Given this list of marker genes EPM2AIP1, LRRC41, ELOA2, PIGN, USP49, NEK10, WEE1, RTKN2, ASH1L, COL1A1, HDAC9, ZFP28, IL1RN, ESRRG, EMP2, TAGAP, ATP6V1A (ATPase H+ transporting V1 subunit A), UBE4B (NCBI Gene Id 10277), BRWD1, SLITRK2, KIAA1217, RBM20, RUNX1T1, PAPSS1, CD164, EFL1, CBX5, HCN1, FBXO8, ZNF154, NRP2, KLF7, BRINP1, ELFN2, SRGAP1, OSBP, SERINC5, KDM5B, NEXN, AAGAB, SORBS1, HECW1, CNTN4, SOAT1, DNAAF2, TRERF1, KRT34, SLF2, AMOTL1, PCYT1A, DDX60L, WDR3, GNG4, ZDHHC9, HGSNAT, LRRC8C, RORA, FBXO5, FBXL5, TGFBR1, RSPH3, PABIR1, GRIK3, PALM2AKAP2, KALRN, SEL1L, LPCAT2, SSU72, GPIHBP1, PTPRB, DNAJA3, STK38, PCNP, PIAS1, ACTR2, ATOSA, LIN54, ESR1, RIPOR2, SMC2, BECN1, ZBTB1, ZNF236, ARRDC3, TMEM245, N4BP1, KLHL14 (NCBI Gene Id 57565), C4orf51, SEPSECS, EGR3, NETO2, C3AR1, CBL, EGLN3, NFIA, AGO1, AGPAT3, STARD5, HLF, UNC119, ALDH6A1, SEZ6 (seizure related 6 homolog), UGT2A1, ZC4H2, AFF1, SOX5, ENPP4, TAB2, SLC6A15, USP6NL, ARHGEF38, UBQLN2, MXRA5, FSD1L, UGGT1, ACBD5, IDI2, SLC41A3, RNF41, TRAK2, DCP1A, H1-0, OTUD4, L1TD1, SORCS3, ZNF709, TTC13, HNRNPUL2, MRPL17, HSPA13, MTMR2, PTEN, GRIK2, TAF2 (TATA-box binding protein associated factor 2), CPT1A, STK35, UTY, PRR27, PEG10, MED13L, CFL2, POU2F1, PBRM1, USP12, DUSP10, DCLK1, ZFP91, FECH, SCML1, USP8, INO80D, SLC7A2, CNGA3, LACC1, NECTIN3, NMD3, WASHC4, GCSAM, ADAT2, FBXO11, GMFB, FAM199X, RSPO4, TSHZ2, GRIA3, CD99, MDGA2, ZYG11B, GATAD2A, CCNG2, MFAP3L, NR4A3, TRAK1, CSN2 (NCBI Gene Id 1447), TCF12, TMA16, STIM2, TBCB, TUBB2B, ZNF566, RETREG1, KDM5A, KLHL31 (kelch like family member 31), TTC33, MAF, AZI2, PABPN1, PFKFB2, SREK1 (NCBI Gene Id 57833), NPTN, MAPKAPK2, SLC6A14, UBE2C, SLC35E1, REV3L, NUDT11, AMMECR1, DLGAP5, UBE2Z, SCML2, BMPR2, TMF1, RUFY2, GK5, BBOX1, AFAP1, TBK1, SALL2, PAX5, TRUB1, PDE11A, FKTN, HYOU1, C16orf82, NALCN, HIPK3, MITF, BPNT2, HYCC2, TNRC6B, LIN28A, NAA30, ARNT, GCLC, ZBTB18, TSSK1B, ALKBH5, ZMYM1, ELOVL2, PRKCI, FAM114A2, PCDHB16, COLCA1, ZNF264, TBC1D30, DDX46, CLHC1, KAZN, SEPTIN10, EXOSC7, FOXK1, LATS2, TMCC1, CEP120, CCNT2, FBXO25, DSE, KCNA1, EBF3, WASF1, PDS5A, FOXO1, PELI1, SOSTDC1, TET3, SOCS4, SPO11, NAA50, APAF1, DCUN1D3, DUOX2, RNF141, LPP, PCGF3, SAMD8, MPP4, NCAM1, SP4, MTMR4, MDM4, TMEM154, SMARCC1, ZNF608, MS4A18, ATPSCKMT, PARP11, PCNX1, ARNT2, CAV1, SYN3, AKT3, ACBD3, CLOCK, CCNB3, GPC6, RAB3GAP2, AKAP8, PDE1C, WNK1, MAN1A1 (mannosidase alpha class 1A member 1), MAP3K13 (NCBI Gene Id 9175), MAP3K9, HLCS, ACSL6, CMTM6, NEXMIF, PELI2, ZNF451, ZNF426, BCAT1 (branched chain amino acid transaminase 1), MED7, WAC, SLC25A24, UNC5C, MAP9, BICRAL, ARPP19, KCTD1, C3orf70, SPRY4, DDX17, SLITRK4, PIK3R3 (phosphoinositide-3-kinase regulatory subunit 3), ERLIN2, RUBCN, DENND1A, TGFA, COPA, CAB39L, SDK1, LARP4, MAP4, CDON, ELP4, ZC3H12C, IKZF5 (IKAROS family zinc finger 5), MS4A12, GPBP1L1, DUSP6, ZBTB20, HOXB3, LMBR1, DLG4 (NCBI Gene Id 1742), NCK2, OR12D3, RIC3, TENT5C, RIMKLB, RAB24, ACIN1, CYP2C18, KLHDC1, FANCM, RRAGB, CXCL5, ADGRL3, TEX12, CRMP1, GFRA1, PAQR9, PICALM, SHANK2, AFTPH, RNF2, PIGA, SLC27A6, NR2C1, VPS33A, NLK, GOPC, SRL, ZNF704 (zinc finger protein 704), CFAP91, FAM135A, ANKRD10, BAZ2B, HMBOX1, CACNA1C, MAP3K7, NEUROD6, ITCH, TBL1XR1, FAM169A, GBP3, RRM2B, FOXP1 (NCBI Gene Id 87246), WAPL, HEXIM1, RFT1, CPSF7, TMEM64, COLEC12, CCNJ, RPRD1A (regulation of nuclear pre-mRNA domain containing 1A), C11orf87, AAK1, RIF1, TMEM41B, ZMAT4, SNX27, SETBP1, RBP1, MYCBP, FAM234B, NAV1, HTR2C, KCNN3, VGLL3, GATAD2B, RNF212B, GALC, PRTG, NRP1, PHF20L1, POLG, ABCD3, GALNT10, TMEM33, SULT6B1, DLX2, PTP4A1, GCM1, DNAL1, DLG1, NUFIP2, SERPINB9 (NCBI Gene Id 5272), CHSY1, COL3A1 (NCBI Gene Id 1281), HIGD1A, ATG3, PLAGL2, ARF6, ANO5, VANGL2, HMGCS1, MTCL3, HSPA9, GABRA4, MAP4K4, ZNF407, TRAF6, ELAVL4, NANOG, ADCY9, SLC11A2, MBTD1, TARDBP, RNF11, DIP2B, TFAP2A, WWC3, RBFOX2, LRP11, CRIPT, SEMA3C, IGSF3, BCL11A, PATL1, HECTD1, ATXN1L, ZNF180, OTUD6B, SLC6A6, LEPROT, RNF38, CSGALNACT1, DISC1, TTPAL, ALG9, B3GALNT2, BLCAP, MYLK, MOSPD2, RNGTT, TXNDC16, IRS1, RSKR, PAICS, SCN1A, ZEB2, UBN2, N4BP2, MKLN1, NABP1, ZNF510, TPD52, SERF2, NGRN, MIP, VPS13A, PSD3, RYBP, NUSAP1, STON2, ATXN3, PHTF2, ARID1A (NCBI Gene Id 8289), TAOK1, ANO1, BNC2 (NCBI Gene Id 54796), BIRC3, SMG6, ELAVL2, TAB3, ONECUT2, GTF2A1, FOXN3, CAMK4, NUPR2, SF3B6, TRIM8, CHD1, DGKH, SGIP1, PGM2L1, UBE2B, ABCC9, TMEM108, NSF (NCBI Gene Id 4905), VGLL2, TPD52L2, PUM2, IGF1, CPSF6, FSTL1, TBXA2R, PRRC2B, ENPP3, BEST3, ZNF805, RBPJ, ATP1B1, EDN1, RASGRP1, PPP3R1, HNRNPA2B1, GORAB, PGRMC2, PAQR3, SLC14A1, XPR1, GNB1, ZBTB41, DESI1, EPHA7, NFASC, PRPS2, ASCL1, NCK1, EGR4 (NCBI Gene Id 82930), CNTNAP2, POGLUT1, F2RL2, POLR1H, CELF1, HOOK3, IGDCC4, MAP3K21, NUFIP1, NFAT5, SERPINB5, ETV3, APLP2, TTC21B, MGAT4A, DCX, GOLPH3L, ATP8B1, GPR37, SYNPO2L, AMER2, RAB39B, MAP3K20, PTER, KLF6, PPM1L, THSD7A, BOD1L2, UQCRB, ZXDA, GSK3B, ATP1B4, MAX, PROSER2, CILK1, CNOT6, FMO5, TMX4, FBXL3, ETNK1, FXR1, SUPT5H, EHD4 (NCBI Gene Id 30844), ARIH1, SRSF3 (NCBI Gene Id 6428), IKZF3, NSL1, AFAP1L1, WDR26, TRAPPC2, FLRT3, DNAI7, TSPAN6, TANC2, SLC6A11, MIER3, PPP2R5E, RAP2C, AP3M2, PHF6, CTNND1, TPM4, LEF1, SLC22A15, IL20RA, SNRNP48, MIA2, GALNT3, ZNF703, SLC12A5, SPIN4, KMT2C, BCL2L2-PABPN1, SRP54, LRRC8B, ASPHD2, BCL11B, GLYATL2, FOXM1, SH3RF1, MN1, SIM1, LPCAT1, CLUAP1, TMEM215, CORO1C, YWHAG, MMS22L, EPB41L1, FKBP14, POLR1F, SCAI, RERE, DCUN1D5, LCORL, ZFHX3, UBL3, RAB8B, PRAMEF19, RFX3, KIRREL1, EIF3J, ITGAE, CCNDBP1, PHF24, SEC23A (SEC23 homolog A, COPII coat complex component), GUCY1A2, KRTAP4-7, EFR3A, CDC42EP3, RASGRF2, YWHAQ, CDK6, RLIG1, SDE2 (NCBI Gene Id 163859), GLIPR1 (GLI pathogenesis related 1), CPA4, NHLRC3, STK24, TMEM170B, COL25A1, GABRB2 (gamma-aminobutyric acid type A receptor subunit beta2), INTS6 (integrator complex subunit 6), RIOX1, C3orf38, PIK3C2A, IPO5, TBX5, USP37, SOX6, NR6A1, CDK12, GCLM, N4BP2L1, PRAMEF18 (NCBI Gene Id 391003), FBXO21, SENP7, SORCS2, TMEM138, PERP, GABRA1, NEGR1, TRDMT1, SSH2, SELENOI, VPS53, CLDN12, EIF4H, ALDH1B1, TRPM1, MTMR3, CLEC2D, FUT8, SLC2A13, RAPGEF6, TMEM248 (transmembrane protein 248), PTAR1, TLL2, ADAMTS6, RMND5A, TTC28, MFAP3, MKNK2, RC3H1, PRRG1, USP7, UBFD1, MRPS25, FMR1, CCSER1, KIAA0408, KRAS, TRIM2, C5orf24, EDIL3, ZXDB, GABRB3, SHROOM3, SEC61G, ZFP82, CNOT6L, PCK1, ZDHHC21, AMER1, RPRM, CPNE8, CSRNP3, FBXO28, PRKAR2B, TNPO1, UGT2A2, TAPT1, LAMP3, GPSM2, PTP4A2, EMX2, SEMA6A, KAT6B, FRMD5, ENTPD7, NAP1L4, CADM1, NCKAP5, RRP15, PTMA, PCNX4, TAS2R5, BCHE, ZER1, ATG5, DPP8, QKI, TSPYL4, AK9, SLK, CREB5, RAI1, PRKG2, EEA1, CUL3, EXD1, ARF3, POU3F4, ARMC8, SPAG9, BCL10, MAP3K2, NUAK1, NCOA2, KCTD9, ILRUN, IKZF2, TNFRSF11A, BMAL2, CACNA1G, ERCC4, TAF5L, TBC1D32, DCUN1D4, MRPL15, SLC7A11, KDM7A, FCGR1BP, IPCEF1, LRATD2, NBEA (neurobeachin), MAPKAP1, USP32, COL11A1, CACNA1A, PSEN2, FPGT, CCDC47, PREX2, TRIM66, IDS, ZNF652, CAMTA1, DDAH1, A1CF, PSMD4, KLHL13, CAMKK2, SESN3, SF1, SRSF1, CIPC, PRKCE, ADAR, CDKN1B, ANKIB1, SALL4, IFITM10, EIF4EBP2, GLS, here is a description of the gene set: Human Gene Set: MIR651_3P studied in species Homo sapiens from publication Chen Y, Wang X (PMID 31504780) Genes predicted to be targets of miRBase v22 microRNA hsa-miR-651-3p in miRDB v6.0 with MirTarget v4 prediction scores > 80 (high confidence targets).